The following is a description of a gene set: species: Homo sapiens Human Gene Set: GOBP_METANEPHRIC_TUBULE_MORPHOGENESIS The process in which the anatomical structures of a metanephric tubule are generated and organized from an epithelium. A metanephric tubule is an epithelial tube that is part of the metanephros., and this is the list of marker genes: HES1, LGR4, WNT4, PKD1, SOX9, WNT9B, SOX8, PAX2, HES5, PAX8